The following is a description of a gene set: Leptin-insulin signaling overlap studied in species Homo sapiens Human Gene Set: WP_LEPTININSULIN_SIGNALING_OVERLAP, and this is the list of marker genes: SOCS1, PDPK1, IRS4, LEPR, PIK3R3, SOCS2, JAK2, IRS2, INSR, STAT3, PIK3CG, SOCS3, AKT1, LEP, IRS1, DGKZ, INS